Given this list of marker genes AAGAB, KRT1, CERS3, LIPN, KRT16, POGLUT1, LORICRIN, COL14A1, ALOXE3, WNT10A, ATP2A2, KRT9, ALOX12B, GJA1, CARD14, DSG1, KRT10, GJB3, SERPINB7, PNPLA1, SDR9C7, ENPP1, here is a description of the gene set: Hypergranulosis is an increased thickness of the stratum granulosum. studied in species Homo sapiens Hypergranulosis Human Gene Set: HP_HYPERGRANULOSIS